The following is a description of a gene set: The covalent alteration of one or more nucleotides within snRNA, resulting in a change in the properties of the snRNA. Mouse Gene Set: GOBP_SNRNA_MODIFICATION studied in species Mus musculus, and this is the list of marker genes: Nop10, Larp7, Mettl16 (NCBI Gene Id 76970), Nhp2, Dkc1, Larp7-ps, Mepce, Mettl4